The following is a description of a gene set: Human Gene Set: LIAN_NEUTROPHIL_GRANULE_CONSTITUENTS from publication Lian Z, Wang L, Yamaga S, Bonds W, Beazer-Barclay Y, Kluger Y, Gerstein M, Newburger PE, Berliner N, Weissman SM (PMID 11468144) Although the mature neutrophil is one of the better characterized mammalian cell types, the mechanisms of myeloid differentiation are incompletely understood at the molecular level. A mouse promyelocytic cell line (MPRO), derived from murine bone marrow cells and arrested developmentally by a dominant-negative retinoic acid receptor, morphologically differentiates to mature neutrophils in the presence of 10 microM retinoic acid. An extensive catalog was prepared of the gene expression changes that occur during morphologic maturation. To do this, 3'-end differential display, oligonucleotide chip array hybridization, and 2-dimensional protein electrophoresis were used. A large number of genes whose mRNA levels are modulated during differentiation of MPRO cells were identified. The results suggest the involvement of several transcription regulatory factors not previously implicated in this process, but they also emphasize the importance of events other than the production of new transcription factors. Furthermore, gene expression patterns were compared at the level of mRNA and protein, and the correlation between 2 parameters was studied. (Blood. 2001;98:513-524) species: Mus musculus Granule constituents expressed during mouse promyelocytic cell line differentiation to neutrophils., and this is the list of marker genes: PRG3, CTSD, ELANE, CAMP, MMP9, CTSS, SCARB2, CTSC, CYBB, CTSH, CPA3, ITGB2, MPO, LYZ, GUSB, FPR1, CTSB, CTSE, CTSV, CTSG, MMP13, SRGN, LTF, LCN2, MAN2C1